The following is a description of a gene set: species: Mus musculus Mouse Gene Set: GOMF_RNA_POLYMERASE_II_C_TERMINAL_DOMAIN_PHOSPHOSERINE_BINDING Binding to phosphorylated serine residues in the C-terminal domain of RNA polymerase II., and this is the list of marker genes: Leo1, Pcif1, Rtf1, Scaf8, Scaf4